The following is a description of a gene set: species: Mus musculus The disaggregation of an organelle into its constituent components. Mouse Gene Set: GOBP_ORGANELLE_DISASSEMBLY, and this is the list of marker genes: Skic2, Rnf14, Dyrk3, Rchy1, Gtpbp2, Mtif2, Ascc3, Nemf, Plin2, Rack1, Prkaa1, Zfp598, Hdac6, Plin3, Kif9, Mrrf, Klhdc10, Eif4e2, Chka, Trnt1, Mtrfr, Kif5b, Pnpla2, Plk3, Pelo, Abce1, Plaat3, Gigyf2, Rnf25, Skic3, Hbs1l, Eif2d, Mcts1, Ddrgk1, Ptrh1, Cdk1, Ufl1, Plaat1, Saysd1, Stx5a, Nedd9, Mrpl58, Usp10, Golga2, Ltn1, Skic8, Trip4, Ascc2, Trim21, Elac1, Gfm2 (G elongation factor, mitochondrial 2), Afg2b, Ankzf1, Denr, Cdk5rap3, Gcn1, Vrk1, Aurka, Spast, Rrp7a, Zfand1, Klc1, Kat5, Ufsp2, Mtif3 (mitochondrial translational initiation factor 3), Mtres1, Faf2, Gbf1, Tcf25, Map4, Vcp, Prkaa2, Kif19a (kinesin family member 19A)